The following is a description of a gene set: from publication Schaefer CF, Anthony K, Krupa S, Buchoff J, Day M, Hannay T, Buetow KH (PMID 18832364) Human Gene Set: PID_TCPTP_PATHWAY studied in species Homo sapiens Signaling events mediated by TCPTP, and this is the list of marker genes: VEGFA, KDR, STAT5B, SOS1, JAK1 (Janus kinase 1), PDGFRB, PIK3CD, ITGB1, INS, PIK3R3, STAT6, PIAS1, MET, CSF1R, PTPN2, CSF1, EGFR, RAB4A, HGF, SHC1, EGF, PDGFB, STAT3, PIK3CA, JAK3, PTPN1, STAT1, ITGA1, INSR, SRC, KPNA2 (NCBI Gene Id 728860), KPNB1, PIK3R2, PIK3R1, PIK3CB, LMAN1, STAT5A, CREBBP, GAB1, EIF2AK2, GRB2, ATR